The following is a description of a gene set: Skewfoot studied in species Homo sapiens A type of flat-foot characterized by hindfoot abductovalgus, metatarsus adductus, and Achilles tendon shortening. The predominant radiographic findings include forefoot adduction with lateral subluxation of the navicular on the talus and heel valgus. Very abnormal shoe wear is noted on the medial side. Calluses occur under the metatarsal heads and the head of the plantar-flexed talus. Human Gene Set: HP_SKEWFOOT, and this is the list of marker genes: ATP1A3, SLC26A2, SLC1A3, NDRG1, CACNA1A, ATP1A2